Given this list of marker genes Tmem165, Ank1, Armc8, Ccn5, Doc2b, Lrit1, Fgf12, Tpmt, Cenpk, P4ha3, Npr3, Lyn, Thsd4, Ptprd, Mup15, Lsm12, Pitpnm3, Ap1s3, Hectd4, Zfp503, Cnot4, Dmac2l, Atxn1, Pkib, Sox12, Mup7, Dpysl2, here is a description of the gene set: Genes predicted to be targets of miRBase v22 microRNA mmu_miR_2136 in miRDB v6.0 with MirTarget v4 prediction scores > 80 (high confidence targets). species: Mus musculus Mouse Gene Set: MIR_2136 from publication Chen Y, Wang X (PMID 31504780)